Given this list of marker genes Pik3r1, Jak2, Leprotl1, Gh, Ptk2, Star, A1bg, Mbd5, Jak3, Pxn, Leprot, Adrm1 (adhesion regulating molecule 1 26S proteasome ubiquitin receptor), Shoc2, Stat3 (signal transducer and activator of transcription 3), Jak1, Stat5b (NCBI Gene Id 20851), Stat5a, Gdf15, Socs2, Ghr, Tyk2, Stat6, here is a description of the gene set: Any process that results in a change in state or activity of a cell (in terms of movement, secretion, enzyme production, gene expression, etc.) as a result of a growth hormone stimulus. Growth hormone is a peptide hormone that binds to the growth hormone receptor and stimulates growth. species: Mus musculus Mouse Gene Set: GOBP_CELLULAR_RESPONSE_TO_GROWTH_HORMONE_STIMULUS